The following is a description of a gene set: Toe deformity studied in species Homo sapiens Abnormal positioning of toe phalanges. Deformities of the lesser toes often occur gradually, though they can be brought on by trauma. The main adult sagittal plane deformities consist of claw toes, hammer toes and mallet toes. Axial plane deformities include crossover toes. Human Gene Set: HP_TOE_DEFORMITY, and this is the list of marker genes: RAB3GAP1, PIEZO2, SNRPN, RAB3GAP2, ACTB, INF2, SIGMAR1, VCP, PDZD8, TMCO1, KAT6A, CPT1C, FBN1, GDAP1, SOD1, ITPR3, PPP1R21, MED25, RSPRY1, MAD1L1, BCOR, AARS1, HSD17B4, GJA8, CHP1, LRSAM1, TRPV4, TELO2, ARX, MYOD1, DDX6, SLC6A9, ADCY6, NEFL, SACS, CTU2, SOX5, BPTF, TCF4, PMP2, WIPI2, RAB11B, ZNF407, LMNA, PUF60, VRK1, CCDC47, REEP1, GNPNAT1, SF3B4, NRCAM, MFN2, TPM2, PLEKHG5, FGFR2, ERI1, TMEM94, EZH2, RTN2, SBF2, OTUD6B, GARS1 (NCBI Gene Id 7972), TMEM260, THOC6, USP9X, KIF1B, PHYH, ZFX, MORC2, SLC35A3, MED12, NEK9 (NIMA related kinase 9), ATN1, CHST11, RAB7A, PDXK, EXT2, PRX, PMP22, CREBBP, ASXL1, BLTP1, TOR1A, MPZ, KAT8, MPV17, NDRG1, CHCHD10, SPTAN1, TBCK, INTS8, ESCO2, CCDC22, SLC35C1, SETBP1, GBF1, RTL1, DHCR7, BSCL2, DCAF8 (DDB1 and CUL4 associated factor 8), EGR2, CPLX1 (NCBI Gene Id 10815), INTS1, MYH8, MYH3, TRAF7, BMPER, COA7, ATP6V1E1, MAPK1, CDC42, AEBP1, SH3TC2, GLI3, UBE2A, PEX7, EP300, DLK1, XYLT2, SMAD4, SIN3A, ESAM, SPART, GDF6, HARS1, MEG3, HUWE1, RNU4-2, GNB4, HNRNPK, GJA5, SYT2, PCGF2, EBP